Given this list of marker genes RAD51 (NCBI Gene Id 5888), FANCG (NCBI Gene Id 82603), FANCA, FANCD2, DHX37, UBE2T, FANCE, FANCL, RFWD3, FANCB, PALB2, GDF6, BRCA2, RAD51C, TCTN3, ERCC4, FANCF, BRIP1, FANCI, FANCM, MAD2L2, SLX4, FANCC, XRCC2, BRCA1, here is a description of the gene set: Human Gene Set: HP_ABSENT_TESTIS Testis not palpable in the scrotum or inguinal canal. studied in species Homo sapiens Absent testis